The following is a description of a gene set: from publication Chen Y, Wang X (PMID 31504780) studied in species Mus musculus Genes predicted to be targets of miRBase v22 microRNA mmu_miR_374b_3p in miRDB v6.0 with MirTarget v4 prediction scores > 80 (high confidence targets). Mouse Gene Set: MIR_374B_3P, and this is the list of marker genes: Dennd6a, Clock, Srgap2, Klf8, Akirin1, Fbxo45, Zfp68 (NCBI Gene Id 24135), Fign, Cdh12, Ido1 (NCBI Gene Id 15930), Reg3a, Cd207, Cep97, Gpr4, Map3k21, Brs3, Ccar1, Dlg2, Abhd18, St7l, Dusp1, Yy1, Saal1, Vezf1, Mbnl3, Arap2, Dmac2l, Bicd2, Marchf1, 1810010H24Rik, Rap2a, Yy2, Serpinb7, Elavl2, Mettl21c, Rasa1, Snai2, Zfp790, Ifi202b